Given this list of marker genes GJD2, GJC1, GJA10, PANX1, PANX2, here is a description of the gene set: species: Homo sapiens Reactome Pathway: Electric Transmission Across Gap Junctions Electrical synapses are found in all nervous systems, including the human brain. The membranes of the two communicating neurons come extremely close at the synapse and are actually linked together by an intercellular specialization called a gap junction. Gap junctions contain precisely aligned, paired channels in the membrane of the pre- and postsynaptic neurons, such that each channel pair forms a pore. Electrical synapses thus work by allowing ionic current to flow passively through the gap junction pores from one neuron to another. Because passive current flow across the gap junction is virtually instantaneous, communication can occur without the delay that is characteristic of chemical synapses. part of: Transmission across Electrical Synapses 